Given this list of marker genes WDR64, C16orf46, CDC25A, CLN6, ITGA8, RTKN2, NFKB1, CBLN1, SNAP25, DUSP15, FUT8, RLN1, HBEGF (heparin binding EGF like growth factor), PCGF5, TBX21, C3orf52, CCL25, RAPGEF5, C11orf52, HSF5, MXI1, LAG3, NUDT11, B3GLCT, CKB, CDH7, GIMAP4, IL6, CHST11, ZNF616 (NCBI Gene Id 90317), CREB5, CALN1, NAPEPLD, ENTPD6, SOCS2 (suppressor of cytokine signaling 2), TNFAIP6, RBFOX1, PTH1R, PFDN2, DENND5A, PPP1R1C, RAB34, ARRDC5, HMGCLL1, PXN, UBTFL1, TMEM214, ARL4C, ZFAT, PUS7, SPAG16, CDON, MBOAT2, HYCC1, CARD6, TSPAN2, CLDN8, CDX4, DACH1, CYLC2, ETV2, PLXND1, CHRNA2, RIMBP3C, MEIOC, CCR7, PNMA8B, RPS6KA2, ADGRL3, DZIP1L, CLEC12B, TET2, CSMD3, NBEA, SLC17A2, ACTN1, CST7, TLCD1, IGFBP4, PLXNC1, GPR182, JUN, BCL2L1, MAMDC4, UNC79, GRHL1, CPM (carboxypeptidase M), KIAA0040, BHMT, BNC1, BATF, BMP1, GABRB2, XCL1, ATP8B2, TNFSF14, HNF1B, CLCF1, ADAM19, ZIC4, WEE1, EPS8L2, CACNA1B, SLC17A6, HSD11B1, MUSK, RNF133 (NCBI Gene Id 168433), PERP, SYTL3, NIBAN3, PRND (prion like protein doppel), MLLT6, AIF1, OR52A1, DENND3, RNF222, CD44, RNF180 (ring finger protein 180), SOCS3, RFX5, SH3GL3, TRPV1, PALMD, EBI3, ZNF423, EREG, GPR146 (NCBI Gene Id 115330), KCNA5, CACNA1S (NCBI Gene Id 779), MMP2, INO80E, THY1, SGCD, PRRX2, ERG28 (ergosterol biosynthesis 28 homolog), ADCY8, PLAG1, KCNAB3, CCDC18, GPX7, ENDOU, CCDC85A, BRWD3, CD200, SUV39H2, CFLAR, IL2RA, MISFA, PTH2R, CD81, IFNLR1, IL12B, UCP1, RNF144A, LIPG, C21orf91, TPK1, GADD45B, MPZ, MIOX, CACNA2D3 (NCBI Gene Id 55799), FBXL21P, EMX2OS, SCN1A, TENM4, SCML2, SERPINB9, SLC4A9, RHBDL3, DDX11, HAO1, SLC7A3, C8orf34, HTR3B, KCNMB2, BTBD3, LTA, FCRL1, UNCX, CARD10, HOXB1, GRIK2, SLAMF1, BSPRY, PARD6G, DRC12, KSR1, C1QL3, STARD8, SAMD4A, ABHD3, MYH4, AEBP2 (AE binding protein 2), TM4SF20, CRHR2, IFITM2, SERPINB4, SWAP70, here is a description of the gene set: Genes down-regulated in follicular helper CD4 SMARTA T cells (Tfh): effector during acute infection of LCMV versus memory. from publication Hale JS, Youngblood B, Latner DR, Mohammed AU, Ye L, Akondy RS, Wu T, Iyer SS, Ahmed R (PMID 23583644) Human Gene Set: GSE43863_DAY6_EFF_VS_DAY150_MEM_TFH_CD4_TCELL_DN CD4 T follicular helper (Tfh) cells provide the required signals to B cells for germinal center reactions that are necessary for longlived antibody responses. However, it remains unclear whether there are CD4+ memory T cells committed to the Tfh lineage after antigen clearance. Using adoptive transfer of antigen-specific memory CD4+ subpopulations (based on CXCR5 and Ly6c expression)in the LCMV infection model, we found that there are distinct memory CD4+ T cell populations with commitment to the Tfh and Th1 lineages. Our conclusions are based on gene expression profiles, epigenetic studies and phenotypic and functional analysis. The gene expression profiles of virus-specific CD4 T cell subets at effector and memory stages is presented here. species: Homo sapiens